Given this list of marker genes Fgl2, Klf4, Lyz2 (lysozyme 2), Cd81, H2az1, Alox5ap, Ramp1, Hepacam2, Cxcl9, Klf2, Dock10, Pid1, P3h2, Clec12a, Fuca1, BC028528, Ier5, Mndal, Ccr2, Pmaip1, Plac8, Eif3e, Ly86, Phf11b (NCBI Gene Id 236451), Cox7a2l, Ifi209, Hspa1b, here is a description of the gene set: Cytokines mediate cell-cell communication in the immune system and represent important therapeutic targets. A myriad of studies have highlighted their central role in immune function, yet we lack a global view of the cellular responses of each immune cell type to each cytokine. To address this gap, the authors created the Immune Dictionary, a compendium of single-cell transcriptomic profiles of more than 17 immune cell types in response to each of 86 cytokines (>1,400 cytokine-cell type combinations) in mouse lymph nodes in vivo. A cytokine-centric view of the dictionary revealed that most cytokines induce highly cell-type-specific responses. For example, the inflammatory cytokine interleukin-1β induces distinct gene programmes in almost every cell type. A cell-type-centric view of the dictionary identified more than 66 cytokine-driven cellular polarization states across immune cell types, including previously uncharacterized states such as an interleukin-18-induced polyfunctional natural killer cell state. Mouse Gene Set: CUI_CDC1_IL13_RESPONSE_DN species: Mus musculus Genes negatively differentially expressed in cell type: cDC1 (conventional dendritic cell type 1) upon treatment with cytokine: IL-13 in mouse lymph nodes in vivo. from publication Cui A, Huang T, Li S, Ma A, Pérez JL, Sander C, Keskin DB, Wu CJ, Fraenkel E, Hacohen N (PMID 38057668)